The following is a description of a gene set: species: Mus musculus Binding to Myogenic Regulatory Factor (MRF), a member of the basic Helix-Loop-Helix (bHLH) superfamily of transcription factors. Mouse Gene Set: GOMF_MRF_BINDING, and this is the list of marker genes: Crebbp, Kdm1a, Klf5, Bhlhe41, Bhlhe40, Csrp3